Given this list of marker genes Rps6, Rsrp1, Tyrobp, Mrgpra2b, Slpi, Retnlg, Rps19, Orm1, Rps7, Fcer1g, Rps18, Rpl8, H2-D1, Fth1, Rpl24, Rps8, Jchain (immunoglobulin joining chain), Rpl13a, Tspo, Ifitm3, Lgals3, S100a6, Rpl17 (NCBI Gene Id 319195), Cox5a, Ffar2, Malat1, Ifitm6, Rps9, Rbm3, Rpl35, Ifitm2, Rpl32, Rps14, Cd52, Pirb, Camp, Rpl10, Rpl18a, H2-K1, Mcemp1, here is a description of the gene set: studied in species Mus musculus from publication Tabula Muris Consortium (PMID 32669714) Mouse Gene Set: TABULA_MURIS_SENIS_MARROW_MEGAKARYOCYTE_ERYTHROID_PROGENITOR_CELL_AGEING